Given this list of marker genes APBB2, RCHY1, LPAR1, CLPB, PLAU, GDF15, GPM6A, GALNT10, FAM162A, PLP1, TIGAR, CDKN1A, CPA4, SKAP2, SLC7A11, PLD1, IFI44, HSPA4L, here is a description of the gene set: Human Gene Set: KIM_PTEN_TARGETS_UP from publication Kim JS, Lee C, Bonifant CL, Ressom H, Waldman T (PMID 17060456) In an effort to identify genes whose expression is regulated by activated phosphatidylinositol 3-kinase (PI3K) signaling, we performed microarray analysis and subsequent quantitative reverse transcription-PCR on an isogenic set of PTEN gene-targeted human cancer cells. Numerous p53 effectors were upregulated following PTEN deletion, including p21, GDF15, PIG3, NOXA, and PLK2. Stable depletion of p53 led to reversion of the gene expression program. Western blots revealed that p53 was stabilized in HCT116 PTEN(-/-) cells via an Akt1-dependent and p14(ARF)-independent mechanism. Stable depletion of PTEN in untransformed human fibroblasts and epithelial cells also led to upregulation of p53 and senescence-like growth arrest. Simultaneous depletion of p53 rescued this phenotype, enabling PTEN-depleted cells to continue proliferating. Next, we tested whether oncogenic PIK3CA, like inactivated PTEN, could activate p53. Retroviral expression of oncogenic human PIK3CA in MCF10A cells led to activation of p53 and upregulation of p53-regulated genes. Stable depletion of p53 reversed these PIK3CA-induced expression changes and synergized with oncogenic PIK3CA in inducing anchorage-independent growth. Finally, targeted deletion of an endogenous allele of oncogenic, but not wild-type, PIK3CA in a human cancer cell line led to a reduction in p53 levels and a decrease in the expression of p53-regulated genes. These studies demonstrate that activation of PI3K signaling by mutations in PTEN or PIK3CA can lead to activation of p53-mediated growth suppression in human cells, indicating that p53 can function as a brake on phosphatidylinositol (3,4,5)-triphosphate-induced mitogenesis during human cancer pathogenesis. studied in species Homo sapiens Genes up-regulated in HCT116 cells (colorectal carcinoma) upon knockout of PTEN.